The following is a description of a gene set: A pocket of pus located within a region of a tooth. Human Gene Set: HP_TOOTH_ABSCESS species: Homo sapiens Tooth abscess, and this is the list of marker genes: CLCN7, NTRK1 (NCBI Gene Id 7825), PHEX, ENPP1, DLX3, FGF23, ELANE, DMP1